Given this list of marker genes Rack1, Pcolce2, Wdr20 (WD repeat domain 20), Psme4, Malt1, Tnfrsf10b, Fbln1, Rps27l, Elp2, Apaf1, Psenen, Psme1, Casp8, Fn1, Hspd1, Tank, Atp2a3, Acrbp, Psmd14 (NCBI Gene Id 98839), Ncstn, Cav1, Pcolce, Ngf, Nkx3-1, Casp8ap2, Tifab (NCBI Gene Id 212937), Dmwd, Prss22, Svbp, Bcl10, Vsir, Wdr20rt, Adrm1b, Adrm1, Vcp, Lgmn, Clpx, Aim2, App, Pycard, Aph1b, Sfrp2, Ctsh, Timm50, Psme2, Mapk9, Cflar (NCBI Gene Id 98571), Mmp25, Bad, Wdr48, Ctsc, Nlrp1b, Nlrp3, Aph1a, Aph1c, Psme3, Nlrp1a, Rock2, Tgfb1, Nlrc4, here is a description of the gene set: Binds to and increases the activity of a peptidase. Mouse Gene Set: GOMF_PEPTIDASE_ACTIVATOR_ACTIVITY studied in species Mus musculus